Given this list of marker genes Ppp1r14b, Ran, Wdfy4, Pfkp, Sys1, Eif4a1, Psmb5, Hspa9, Psmd3, Fkbp2, Ctsz, Lrrc59, Snx3, Psmd13, Srsf3, Efhd2, Aimp2, Plbd1, Eif2b2, Ak2, AA467197, Ostc (oligosaccharyltransferase complex subunit (non-catalytic)), Idh3a, Cops5, Casp6, Kpnb1, G3bp1, Ece1, Atp5mc1, Srsf9, Ncl, Sfxn1, Eif5a, Apol7c, Chchd10, Sdc4, Hfe, Eif4e, Rars1, Syngr2, Vasp, Cd84, Gnl3, Lgals3, Ms4a6c, Dynll1, Calm1, Srsf2, Creld2, Lsm7 (LSM7 homolog, U6 small nuclear RNA and mRNA degradation associated), Nubp1, Hspa4, Polr2f, Psap, Copz1 (NCBI Gene Id 80513), Ttc39a, Timm8a1, Apex1 (NCBI Gene Id 11792), Srm, Gspt1 (NCBI Gene Id 98017), Eif6, Mrpl12, Glrx, Ms4a6d, Vrk1, Hnrnpu, Set, Ddx21, Smarca4, Nme1, Ruvbl1, Ptpn1, Ccnd3, Olfm1, Gsn, here is a description of the gene set: Mouse Gene Set: CUI_CDC1_IL13_RESPONSE_UP Genes positively differentially expressed in cell type: cDC1 (conventional dendritic cell type 1) upon treatment with cytokine: IL-13 in mouse lymph nodes in vivo. Cytokines mediate cell-cell communication in the immune system and represent important therapeutic targets. A myriad of studies have highlighted their central role in immune function, yet we lack a global view of the cellular responses of each immune cell type to each cytokine. To address this gap, the authors created the Immune Dictionary, a compendium of single-cell transcriptomic profiles of more than 17 immune cell types in response to each of 86 cytokines (>1,400 cytokine-cell type combinations) in mouse lymph nodes in vivo. A cytokine-centric view of the dictionary revealed that most cytokines induce highly cell-type-specific responses. For example, the inflammatory cytokine interleukin-1β induces distinct gene programmes in almost every cell type. A cell-type-centric view of the dictionary identified more than 66 cytokine-driven cellular polarization states across immune cell types, including previously uncharacterized states such as an interleukin-18-induced polyfunctional natural killer cell state. studied in species Mus musculus from publication Cui A, Huang T, Li S, Ma A, Pérez JL, Sander C, Keskin DB, Wu CJ, Fraenkel E, Hacohen N (PMID 38057668)